The following is a description of a gene set: studied in species Mus musculus Mouse Gene Set: GOBP_NEGATIVE_REGULATION_OF_VASCULAR_ASSOCIATED_SMOOTH_MUSCLE_CELL_PROLIFERATION Any process that stops, prevents or reduces the frequency, rate or extent of vascular smooth muscle cell proliferation., and this is the list of marker genes: Rbm10, Prkg1, Gna13, Efemp2, Cnn1, Cdkn1a, Gna12, Ndrg2, Hmox1, Il10, Tpm1, Mef2c, S1pr2, Mfn2, Timp3, Pten, Rhoa, Gstp2, Rgs5 (regulator of G-protein signaling 5), Agt, Myocd, Tafa5, Pdcd4, Gper1, Park7, Pparg, Sod2, Apln, Cav1, Gstp1, Tgfb3, Cdkn1b, Adipoq, Drd4